The following is a description of a gene set: studied in species Mus musculus The regrowth of a lost or destroyed animal organ. Mouse Gene Set: GOBP_ANIMAL_ORGAN_REGENERATION, and this is the list of marker genes: Phb1, Baat, Med1, Cad, Anxa3, Upf2, Hfe, Ccl2, Ptpru, Wnt1, Apoh, Serpina10, Apoa1, Ggt1, Slc7a5, Gata1, Rpl10, Ace, Pfkfb1, Angpt2, Gas6, Ezh1, Bak1, Gli3, Aurka, Il6 (interleukin 6), Lif, mt-Cytb, F7, Nr0b2, Adm, Cxcl12 (C-X-C motif chemokine ligand 12, NCBI Gene Id 20315), Egfr, Lifr, Lcp1, Ugt1a1, Ihh, Pnpt1, Tyms, Gfer, Ucp2 (NCBI Gene Id 22228), Reg1, Cdk1, Pkm, Itpr1, Csnk2a1, Cebpb, Ptpn3, Cxcl5, Nnmt (nicotinamide N-methyltransferase), Notch1, Cdkn1a, Fpgs, Adh1, Tgfb1, Gstp1 (glutathione S-transferase, pi 1), Cldn1, Ezh2, Ptch1, Pcna, Tnf, Gli1, Sulf2, Axl, Igf2r, Vtn, Il10, Rgn, Ccna2, Atic, Hmox1, Ccnd1, Apoa2, Cpb2, Cpt1a, Pdx1